The following is a description of a gene set: Human Gene Set: GOBP_TRABECULA_MORPHOGENESIS The process of shaping a trabecula in an organ. A trabecula is a small, often microscopic, tissue element in the form of a small beam, strut or rod, which generally has a mechanical function. Trabecula are usually but not necessarily, composed of dense collagenous tissue. species: Homo sapiens, and this is the list of marker genes: NACA, ADGRG6, HEG1, SEMA4D, ADAMTS1, VEGFA, RHOA, FHL2, FBN2, MMP2, CHD7, FOXH1, EGLN1, BMP10, UBE4B, TGFBR3, ENG, SLC40A1, RBPJ, RBP4, NKX2-5, OVOL2, GREM1, S1PR1 (sphingosine-1-phosphate receptor 1), NOTCH1, NRG1, BMPR1A, CHAD, COL1A1, MED1, THBS3, DLL4, BMP5, HEY1, SOS1, TGFB2, SBNO2, TEK, SFRP1, SRF, HEY2, WNT10B, TGFBR1, NOG, CAV3, FKBP1A, BMP7, MSX2